The following is a description of a gene set: Human Gene Set: GSE6269_HEALTHY_VS_STAPH_PNEUMO_INF_PBMC_DN from publication Ramilo O, Allman W, Chung W, Mejias A, Ardura M, Glaser C, Wittkowski KM, Piqueras B, Banchereau J, Palucka AK, Chaussabel D (PMID 17105821) Each infectious agent represents a unique combination of pathogen-associated molecular patterns that interact with specific pattern-recognition receptors expressed on immune cells. Therefore, we surmised that the blood immune cells of individuals with different infections might bear discriminative transcriptional signatures. Gene expression profiles were obtained for 131 peripheral blood samples from pediatric patients with acute infections caused by influenza A virus, Gram-negative (Escherichia coli) or Gram-positive (Staphylococcus aureus and Streptococcus pneumoniae) bacteria. Thirty-five genes were identified that best discriminate patients with influenza A virus infection from patients with either E coli or S pneumoniae infection. These genes classified with 95% accuracy (35 of 37 samples) an independent set of patients with either influenza A, E coli, or S pneumoniae infection. A different signature discriminated patients with E coli versus S aureus infections with 85% accuracy (34 of 40). Furthermore, distinctive gene expression patterns were observed in patients presenting with respiratory infections of different etiologies. Thus, microarray analyses of patient peripheral blood leukocytes might assist in the differential diagnosis of infectious diseases. Genes down-regulated in comparison of peripheral blood mononuclear cells (PBMC) from healthy donors versus PBMC from patients with acute S. pneumoniae infection. species: Homo sapiens, and this is the list of marker genes: SOCS3, TRIM25, CIDEB, EIF1, IFNGR2, ANG, LAMP2, LTF, GK, GNS, FUT4, PLIN3, LGALS3, PCBP2, BST1, CD14, CD93, CSF2RA, FURIN, DAZAP2, GPX3, FCN1, NCF4, NINJ2, STX12, FPR1, CEACAM6, PPIF, SLC35F6, CXCL8, EIF5A, BCL3, DEFA1, COL17A1, CDA, PLEK (pleckstrin), KLF4, TFE3, SLC25A37 (solute carrier family 25 member 37), FCGR1A, HBG1, IMPA2, MAP1A (NCBI Gene Id 4132), S100A8, CLEC5A, FCAR, STAB1, RNASE2, IFNGR1 (NCBI Gene Id 3459), GSN, ITGA2B, MICAL2, FGFR2, CEACAM8, S100A12, CTIF (NCBI Gene Id 9811), ADM, GRN, SPI1, ABCC6, PRDM2, LCN2, PGD, PRTN3, CPD, SLC16A1, MCFD2, CSF2RB, TIMP2, MYL9, ACTL7B, VCAN, CYBRD1, DUSP3, CHST3, CTBS, SIRPAP1, GNAQ, MARCHF2, SDCBP, PTK2B, FOS, ELANE, TOM1, EPHX1, QPCT, SLC22A4, LAPTM4A, MBOAT7, TSPO (NCBI Gene Id 706), SERPINB8, F5, MS4A4A, NPL, CD302, DEDD, HTR3A, CD33, CD163, H1-0, S100P, PLEC, HOMER3, ADAM9, PTGIR (NCBI Gene Id 5739), CSF3R, GRB2, CAMP, PELI2, SORT1, CHMP3, GLUL, ZYX (zyxin), QSOX1 (quiescin sulfhydryl oxidase 1), SNCA, CD36, PLLPP1, ANXA9, PLAUR, CD63, CAST, TPP1, ZMIZ1, FADS1, CYP1B1, IL1RN, SERPINB1, BNIP3L, BPI, RNF19B, RAB3D, ENTPD1, AZU1, BCL6, CLTCL1, STEAP3, APLP2, MPO, PLBD1 (NCBI Gene Id 79887), CYP51A1, EGR1, CHSY1, PLP2, RAB1A, ACSL1, CTSS, COL9A3, VEGFA, CKAP4 (NCBI Gene Id 732190), PKD1L1-AS1, CCPG1, DYSF, VAMP3, ARHGEF11, S100A9, CYBB (NCBI Gene Id 1536), WDFY3, IL13RA1, BLVRB, CRTAP, ANGPTL2, TRIO, DEFA4, HBS1L, FLVCR2, CTNNBIP1, BAG4, ALDOA, PPT1, ADIPOR1